The following is a description of a gene set: species: Homo sapiens from publication Yevshin I, Sharipov R, Kolmykov S, Kondrakhin Y, Kolpakov F (PMID 30445619) Genes containing one or more binding sites for (RYBP) in their promoter regions (TSS -1000,+100 bp) as identified by GTRD version 20.06 ChIP-seq harmonization. Human Gene Set: RYBP_TARGET_GENES, and this is the list of marker genes: NFKB2, DUSP26, PRDM16-DT, HSPE1, RPS13, GPATCH8, ZNF24, JUN, HES1, AIDA, POLR2H, GNB2, DOCK9-DT, PLEC, HOXC4, KMT5B, HMGN5, LINC00240, LIMD1-AS1, MTCL1, LBX1-AS1, EP300, GATA3, NBL1, LTA4H, TCTN3, KLC4, SINHCAF, LTC4S, REXO4, NFIC, FAM185A, METTL25, SNORD95, HMGA2, FAM20B, CALM2, STX16-NPEPL1, PLXNC1, PRR5, TESK1, POLR1G, AATBC, TRIM9, CHRNA3, RPL36A, HOXA10, LINC02960, VTRNA1-2, DHRSX, TOR1A, PKN2, SERINC2, STX11, CALB1, METTL15 (methyltransferase 15, mitochondrial 12S rRNA N4-cytidine), BASP1, DOCK9, ZNF8-ERVK3-1, TMOD1, ARF1, AURKAIP1, NUP88, GTF2IP13, COMMD2, GTF2A1-AS1, TIRAP-AS1, TRAPPC2, RNF138, MED30, TENT5C, RTTN, POM121L2 (NCBI Gene Id 94026), GAD1, HIF1AN, AXIN2, MIR4512, MBP, PRKAG2-AS1, CAMK1D, TXNRD1, ABHD15, VGLL2, CDHR1, MSC, CZIB, WBP1, RIMKLB, ANKRD13C, MRPS31, TRABD2A, NISCH, THAP5, CHAC1, TMEM79, AMER1, SPRY4 (NCBI Gene Id 81848), SLBP, TADA3, RTBDN, TTC7A, NEBL-AS1, CSMD2, KIF26A, GOSR2, HSP90AB1, BMS1, TK2, C17orf75 (NCBI Gene Id 64149), RUNDC3A, TTC13, TLN1, EPHA2, CCND2-AS1, WDR11-DT, VWA7 (NCBI Gene Id 80737), RPL12P14, GRIN1, ZNF295-AS1, USP25, ATG12, XPNPEP1, ANG, IGF2BP1, FRMPD4, NPR3, DDX3P2, WDR91, BATF3, RPL27, HOXD8, CNTNAP2, NR1H3, WNT10A, MCIDAS, EXOSC2, UTP11, WBP4, QARS1, CAMK2D, HS3ST2, SEC13, SCD, SDC3, RN7SL688P, DUSP14, ADAMTS9, FAM228B, ALKBH3, PERM1, RGL1, BOLA1, CHUK-DT, RPS29, ZNF165, LINC01547, GRIN2A, ATPSCKMT, DCTPP1, ZNF76, ADSS2, GABRA6, GJB1, KMT2E-AS1, LYPD5, TRMT11, MAPK11, EFEMP1, RPS18, ALOXE3, KCTD16, FAM120B, SPRING1, MRPL3, MRO, ZNF609, XKR9, SLC27A4, DOLK, ABCF1, RRM2, INTS6L, SNX12, H2BC26, ZNF839, SKIDA1, ITGA3, PPM1F-AS1, ACHE, ZNF408, APP, PRDM2, PIKFYVE, SCAPER, VPS29, DLL1, HMX2 (H6 family homeobox 2), SECTM1, SMIM10, MSC-AS1, PHYHIPL, RAB8B, SPAG7, NR4A2, LINC00923, DUSP9, ATF7IP, MSL2, EGLN3, TRPC7, FBXL19, LMX1B, BHLHE40-AS1, RCOR3, CTXND1, HSPA12A, DAB2, TMEM41A, AP1S1, ETNK2, ZNF283, NQO2, RTEL1-TNFRSF6B, SLC35G2, RCOR1, CFLAR, GRM8, SPAG6, INPP4B, DNAJC11, LRRC23, C2CD5, TIMP1, SMC5, MLF2, GPR39, NEIL1, LINC01780, DDX5, CAPNS1, UNC79, TLL2, FBXO31, CORO6 (coronin 6), ANKRD34B, FSTL3, DGAT2, MIR4500HG, GSDMA, WDR36, LINC01918, PDLIM7, RTKN (rhotekin), CXCR4, VPS25, FOXP4, EXOC8, SYT7, SH3GL2, EPC1-AS2, ENY2, IRAK1, UPF2, PTDSS1, TFR2, PSENEN, VSIG10, NR2F2-AS1, DNAJC2, LINC03086, FOSL2, ZNF540, ANKRD19P, EMX2, MAP6, LINC01475, NFIA (NCBI Gene Id 4774), DCAF1, CYB561D2, LRP2, SH3BGRL, EEF1B2, DCP2, IKZF5, THAP9, REL, HNRNPA1, SNAPC5, CABIN1, IFNLR1, ZNF436, VPS26C (VPS26 endosomal protein sorting factor C), CNOT6L, LRRFIP1, CRADD, PFKP, MARCHF3, WNT5B, ZFAND3, COL9A2, SUNO1, BCL11B, PTCHD1, ERCC6, ILF2, COPS2, AP1S3, LONRF3, CACNG4, KCTD10, MTMR4, CYB5D2, NCAM1, DPP9, CXXC5, TNC, SNORA17A, DOCK10, RIPOR1, TMEM121, PI4KA, MED12, TLE3, NUP50 (NCBI Gene Id 26132), DKFZP434A062, PURA, JMJD6, PTEN, MROH1, RPS4X, TM9SF5P, LRRC1, FGFR1OP2, ACBD6, OTUD6B, ZSCAN20, ZWILCH, CDC42SE1, SMG5, NDUFS7, LCN8, SUV39H2, CCDC3, AK5 (adenylate kinase 5), KMT2A, DDX39B-AS1, GPRASP3, VDAC2, NPHS1, EGFR (NCBI Gene Id 1956), PXN-AS1, TTLL7, CENPS-CORT, NPNT, TMUB1, STOML2, AMIGO2, SNRPB, SLC24A1, LINC01586, PCYT1A, ZZEF1, CHD2, GFM2, SLC4A1AP, TMEM132A, COQ6, RABL6, FBN2, CGGBP1, ALDH3A2, SMPD4BP, PIGL, CCNI, MCEE, ENSG00000236846, C2orf76 (NCBI Gene Id 130355), EXOC3L4, UBA5, INTS13, SLC38A1, SOCS2-AS1, C2orf42, SORCS3, SETMAR, ZNF30-AS1, ECHDC2, VTI1A, GNA13, ISL1, WNT3A, SREBF1 (NCBI Gene Id 6720), TRIM25, BCYRN1 (brain cytoplasmic RNA 1), SNHG15, KCTD8, SSBL4P, HTRA1, OPTN, KCNK10, FBLL1, ENSG00000238142, LTBP3, TNK2, CALCOCO1, PAMR1, EIF5A2, ANKRD27, ZBTB45, FIBCD1, PPP6R3, NTRK3, PHF6, ZNF207, FKBPL, NR2F2, DACH2, MIRLET7BHG, TTLL1 (TTL family tubulin polyglutamylase complex subunit L1), SF3A3, MTF2, MAOA, GUCD1, NRAS, RPL5, SMARCD3, OLIG2, LNC-LBCS, STMN3, HMGB1, PROX1-AS1, MNAT1, AOPEP, ZNF629, PSME1, COQ3, PCBP1-AS1, NLRP1, SNHG32, DDX17, RGMB (repulsive guidance molecule BMP co-receptor b), ZNF568, VAMP7, LRRC49 (NCBI Gene Id 54839), PPM1H, MRPL18, SFTA3, PDZD11, EIF1AD, SPX, EXD2, VTRNA1-3, B3GNT7, ATP2A1-AS1, NR2F1-AS1, H4C8, UBC (NCBI Gene Id 7316), ARVCF, SYT6, NRL (NCBI Gene Id 4901), EP400P1, TGFB2, TPRG1L, LEMD1, CRIP2, LARP4, MFSD4A, HLA-F, PPP1R3B, WDR83, NPR1, NDUFA4L2, EMB, LASP1, LRP3, CZIB-DT, POLK, TMEM17, FAM161A, PRKCZ, UAP1L1, SAXO5, ZNF607, ETV4, JKAMP, LINC01556, LINC01117, PRKAR1A (protein kinase cAMP-dependent type I regulatory subunit alpha), STUM, HECW1, FOXO4, RAB3IP, KAZN, AFF1, DHPS, TEDC1, LIMCH1, PPP6R1 (NCBI Gene Id 22870), NCOA7, MKRN5P, NUP133, TMSB15B-AS1, ATP4A, TOB2P1, PRKCE, TSSK3, WLS, MRPL16, STING1, FKBP10, DPF1, TMEM69, GPR161, S1PR5, MBNL3, AGAP2 (ArfGAP with GTPase domain, ankyrin repeat and PH domain 2), SNTG2-AS1, TMED5, GATAD1 (GATA zinc finger domain containing 1), MAGEC2, HOXA7, LINC01415, SNHG7, IGF2-AS, IGF2BP3, WASF4P, ZNF516-AS1, DUSP6, JMJD1C, TFAP2E, TBCB, TYW1, PIP4K2A, IQCH, ADK, PNPLA6, WWOX, MAGEH1, CIDEA, BRCA2, PPP2R2C, WWC2, IGDCC3, ENAH, UBE3B, NTNG1, C10orf88 (NCBI Gene Id 80007), PDE6D, EDRF1-DT (EDRF1 divergent transcript), NME1-NME2, CHPT1, MRGBP, PDE4A, EFCAB7, EPHX1, HMGXB4, ATOH8, SNTG2, NDUFB3, POLR3E, RNFT2 (NCBI Gene Id 84900), MEGF8, MRPS11, HAR1A, MIR6853, RPS26P11, TSPAN12, CNIH3-AS2, CNKSR2, ASIC2, EPHB1, PTPN21, CALY, EHBP1L1, TAF15, SAMD4B, SMG8, VIRMA-DT, MTARC1, GRIK3, JPX (JPX transcript, XIST activator), PTMA, FOXP4-AS1, PARD6A, MAPT, SFSWAP, PSD (pleckstrin and Sec7 domain containing), SEPTIN4, ZNF248, CCKBR, SEMA3B, SNHG5, ATP1B1, ZDHHC6, H3C9P, SPIN1, VWA5B2, PPP1R12A, AJUBA-DT, SPA17P1, LRFN2, AKAP9, GPS1, SP7, P2RX1, INHBB, GSDME, RBSN, ECI2-DT, MYL6, ESAM, PPP5D1P, SMCR8, PECR, RNF157-AS1, SMARCD2, NMNAT1, FAM98B, CCT6B, TRIM45 (tripartite motif containing 45), KLHL21, PLK2, PLXNB3 (plexin B3), NKD2, MSX2, ACOT7, SUDS3, WTAP, NEURL1B, GAS6-DT, NPTX1, CKLF-CMTM1, PTPRS (NCBI Gene Id 5802), MGST3, CCDC122, ADSL (NCBI Gene Id 158), CHEK2, FBXL7, TLE2, KIFC3, SNHG18, SCNN1A (NCBI Gene Id 6337), PVALEF, COX8A, NSA2, CD24, WDR75, EP300-AS1, LSR, CNIH3, LINC01023, TRIM7-AS2, RNU6-9, EMX2OS, S100A2, GBF1, STRA6, FGF9, PSMC2, HCG14 (NCBI Gene Id 414760), RNY3, PTPN12, FIGNL2-DT, PPP1R13L, SACM1L, RNF207, MIF4GD-DT, TAF7, L1CAM, SLC4A11, CELF4, SPOP, TPR, MKX, HSPD1, TNFAIP3, REL-DT, GABPA, RAB27B (RAB27B, member RAS oncogene family), DHX40, ASCC1, LLGL2, KAT5, U2SURP, MIR378A, IKZF2, CREB3, AP3M2, MBLAC2, DIP2C, TFAP2A, SMARCAL1-AS1, HOXB3, COG2, SLC35B1, PSMD3, NOP16, NRP2 (neuropilin 2), HSPA6, LINC01686, SDCCAG8, RNASE11, SGSM2, SLC13A4, GABPB2, ALDH1A2-AS1 (NCBI Gene Id 283665), RNF187, ACE2, DCDC2, C8orf58, F3, ZNF473, PDZD7, MIS12 (MIS12 kinetochore complex component), CASKIN2, INTS14, PRSS16, SPRTN, TPRN, ELOVL1, KMT2D, AASDH, MIR616, HS3ST6, H2BC27P, CERT1, RHBDF1, ANTXR1, ELAVL2, RBM15, LINC00475, OSBPL1A, EDNRB, COX16, NEMP1, EFNA2, MTR, TTC9B, NHSL2, GLIPR1L2, EPIST, ZCCHC7, CHCHD2P6 (coiled-coil-helix-coiled-coil-helix domain containing 2 pseudogene 6), ST3GAL5, SOX3 (NCBI Gene Id 8256), PRPH, RNF25, H2AC25, SHH, NBR1, MIDN, RBBP7, LINC02136, SUFU, SMARCC2, GLI3, KLRG2, WEE2-AS1, TUBGCP6, VSTM2A, ARRDC4, VCPIP1, RPL32, CBR3-AS1, MBD6, CDKN2D, HCN4, C3orf38, BRF2, DNM1P35 (dynamin 1 pseudogene 35), PALS1, MCM10, ALDH1A2, DCP1A, PCGF1, PRAF2, AGBL5-AS1, BTK, LRRC20, VPS51, ERO1B, TIMM9, PIM1, NOG, SLC30A3, STK11, PLAUR, NUMBL, RETSAT, MIR200CHG, DHDDS, SHTN1, DLL4, TSEN54, FOXJ1, EIF3A, PRDM8, EMC3-AS1, SYN3, HNRNPU (NCBI Gene Id 3192), PTPRG, TBC1D19, NDUFA4, CPNE5, DDX47, ENPP3, RBM4B, NPDC1, PIGM, BTG2-DT, NPY, TRPC5, VSNL1, GARS1-DT, THBS3-AS1, ENTPD2, ADGRF2P, FBXO38-DT, FRA10AC1 (FRA10A associated CGG repeat 1), LINC01623, IGBP1, UBE2I, MOAP1, SPATA2L, KIT, COL19A1, CCDC59, FGF13 (fibroblast growth factor 13), PITPNM1, ENSG00000255647 (novel transcript), CBX4, TMEM259, EIF3F, AJUBA, SAR1B, CYREN (NCBI Gene Id 78996), ASAH2B, CCND3, EZH1, TLR5, PPP1R14C (NCBI Gene Id 81706), DMRTA2, TM6SF1, CCDC97, EOLA1-DT, MPHOSPH10, RPL4, SH2D5, FOXA2, VWA1, RAB3IL1 (NCBI Gene Id 5866), DAXX, NUP54, GATA6, SSBP4, CACNB3, LGI4, CAMK2N1, CAPS2, PPP2R3C (protein phosphatase 2 regulatory subunit B''gamma), C5orf34, NSL1, STYXL1, YIPF3, COPS7B, DPF3, RIPPLY2, SLC39A3, CD99L2, DBI, RNF220, PTOV1, COL4A6, PHACTR1, RPP38, ZNF131, INTS10, ECEL1, PPP4R3B, NUP153, BNIP1, CCDC18, ELP2, RERG, PADI1, MICB, ADRB1 (NCBI Gene Id 153), JARID2, CDK5RAP3, DNAAF11, HYCC2, TCP1, CCDC124, RASSF10-DT (NCBI Gene Id 105376557), TOP3A, AEBP2, PARP2, ZNF503-AS1, FIBP, FUZ, SNX2, CWC27, FXYD7, ARPC4, UBAP2, PDE11A, ANKRD13B, NIM1K, MIF4GD, SS18, SASH1, ERCC6L2, WRAP53, CITED1, ICAM4-AS1, HELT, CDK14, LINC03126, PLK3, FLVCR2, LINC02361, SPATA41, TRIM41, APTX, SERTAD3, E2F2, RAD9B, KDM3A, SLCO4A1, RASAL2, FTCD, OBI1-AS1, MCUB, RPTOR, HMCN2 (hemicentin 2), TRPA2P, NXT2, DDX39B, CXCL12, SLC35G1, ZNF846, EXO1, TOP3B, PICART1, PITPNM3, KCNH3, HAUS5-DT, BRPF1, MEPCE, HTR5A, POU4F2, BLOC1S1, DHX33-DT, TAP1, LRMDA (leucine rich melanocyte differentiation associated), TARDBP, TRPV4, ENSG00000176984, TTC5, SEC22B, ABCG4, DIRAS1, ANK3, KCNJ5, ZEB2-AS1, GABBR2, SLC25A53, RN7SKP114, ZBTB8OS (NCBI Gene Id 339487), BPHL, ARPC4-TTLL3, ZNF8-DT, LRPPRC, CSF1, STK36, SMAD7, PLXDC1, ALG10B, PPID, SNRPB2, RRP8, ENTPD1-AS1, IARS1, SH3RF3, ATE1OSP, FOXK2, SKOR2, TICRR, LITATS1, GALNT16-AS1, RAPGEF1, ANKRD40, RTL9, VTRNA2-1, NT5C1A, KRT8, PRORP, RET, ENSG00000224905, WAC, RUBCNL, SFR1, PCNT, GFI1B, GAS2L1, GLI1, GPBP1L1, TEFM, NFASC, HSCB, LTN1 (listerin E3 ubiquitin protein ligase 1), ST6GALNAC2P1, KHSRP, CDIP1, UNC45A, HOXA-AS3, KANSL3, SPAG8, KIAA0586, ZBTB40, NUP188 (nucleoporin 188), ZSCAN12, KNL1, TAPBP, NMB, RNY4, FBXO38, SNORA73A, RN7SK, CCN1, COL15A1, PPEF1, TSPAN31, HDAC1, OAS3, PPARG, MARCKSL1, DYSF, APBA2, MEF2C, SLC29A3, CITED2, NUP50-DT, TBC1D16, ARHGAP1, CHFR, CNTRL, ZNF862, PAN2, LINC02698, RNY1, DGUOK-AS1, KIF4A, PEX3 (NCBI Gene Id 8504), ELMOD1, GDF7, DCLRE1A, MZT2A, SEZ6L, ADCY8, COL24A1, FAAP20, CCDC177, MDH2, MAX, CCDC117, AGBL5, COQ8B, GUCY1B1, CREBL2, TCHP, IGFBP3, TRIM14, KLF2-DT, LSM5, MATK, KRTDAP, CLVS2, POLR1C, NCOR2, CIMIP6, AACS, ENSG00000283183, NUP133-DT (NUP133 divergent transcript), TMEM242, LINC00265, CCND2, PRKCZ-DT, LAMA1, METTL26, HEBP2, ARHGAP4, STOX1, ZFP36, PLEKHO1, FAM32A, GALNT14, EDRF1, MDM2, LINC01116, STRIP2, MRPS31P5, NKX6-2, PAK3, HOMER2, PRRC2C, LINC00620, IREB2, RN7SL1, B4GAT1, PVALB, GMDS, ISLR2, SLC29A1, SFMBT2, FLT4, SBDS, COMMD1, PIANP, DNAJB2, TMEM202-AS1, RANBP17, TSPO, DCAF11, ZNF382, PGD, ZNHIT3, NEFL, ZNF561, H4C4, SBDSP1, CT75, CDC7, HELLS, BCL11A, PCLAF, GFRA2, LPAR1, PXDN, ZNF227, FMC1, INSRR, BAZ1A-AS1, VTRNA1-1 (vault RNA 1-1), KCNF1, EPB41L4B, BANF1, KLHL28, CLUAP1, C15orf40 (chromosome 15 open reading frame 40), CTSC, DAP, CTDSP2, INTS11, LINC01775, CORO7, DRG2, SGMS1, NAPG, GSN, SLC43A1, BRI3BP (BRI3 binding protein), PLEKHG2, DNER, TRPC4, BHLHE40, CRLF1, KCNQ4, RNASE4, RGS5, APBA1, AP3S1, MARVELD1, ACD, B4GAT1-DT, RHBDD2, ACADL, RNVU1-1, SNX33, SNORA14B, RGS9BP (NCBI Gene Id 388531), BCL7C, CYP1A1 (cytochrome P450 family 1 subfamily A member 1), KRT13, FBXO17, TOX4, SLC12A9, ATRAID, MED26, CHAT, ADAMTS7P4, ARL15, SEMA3G, MIR3939, MED16, AAGAB, ARMCX6, ERMP1, NQO2-AS1, SOX14, ADAP2, NBAS, STAT3, NR4A1, SOX6, GRAMD1A, NDRG1, SYTL4, BHLHE22-AS1, LHFPL4, FSD1L, IRS4-AS1, DEPDC1B, ANKRD34A, POLG, ZNF711, OTUD6B-AS1 (OTUD6B antisense RNA 1 (head to head)), RUSC1, DMAP1, GOSR2-DT (NCBI Gene Id 105371798), PSMF1 (proteasome inhibitor subunit 1), SP6, P2RX6, FAM133B, MIR6821, LINC00963, HOXA5, ILK, SF3B6, MIR4734, GSR, FHL1, TAFA2, MAGEE2, LINGO1, PCSK1, ZNF461, VRK3, TSR1, PPP4R3B-DT, SLC35E4, BMP4, INSIG2, GABARAP, HES2, ID3, ZNF35, POLR2I, FSCN1, TMX3, RPS15, PER1, PLEKHD1, DIP2A, RAB29, MPP1, LINC00663 (NCBI Gene Id 442764), NOL8, GARS1, HOXD11, CYB5R4, MTIF2, SP2-AS1, SATB2-AS1, NKX2-1, PHACTR2, PRMT5, RPAIN, STAG2, TMEM105, TNS3, OLFM2, CBR1, NEMF, GBA1LP, CDC42EP4, UBE2L6, ENSG00000247416, ARMC3, NDUFAF4P1, SYNGAP1, KIF26A-DT, PPP1R18, RPP38-DT, DCAF8, ZEB2, IL23A, ZNF383, PLEKHF1, RPL37A, MDH1, NOC3L, RRS1-DT, COSMOC, ELANE, ACTR1A, CCDC107, IGF2, SLC8A3, PDCD6, RAB2B, KLF2, VPS52, DSC2, HJV, UBB, ZNF592, MRPL2, PARD3B, ITGB3BP, ETV6, BCAR3, SNORA9, TSC1, LINC01210, SNRPD3 (small nuclear ribonucleoprotein D3 polypeptide), EGR3, EMC4, ELMOD3, SPAG16-DT, GRIA4, GINS3, ZNF30, TMEM242-DT, S100A10, AHSA2P, SLC27A6, STK10, RARG, PRKCG, SMG7-AS1, PLXNA2, ATG4B, CYP26A1, NHEJ1, IQGAP2, PRKG1, SPTBN4, NAB2, PTPRB, QKI, BROX, PCED1B, RPL36A-HNRNPH2, BHLHE41, PHLDB3, ADCYAP1, RBL1, NINJ1, DGAT2-DT, SLC16A2, KY, TAF6, GPRC5C, SPAG16, CYP2R1, NANOS3, GHET1, NPC1 (NCBI Gene Id 4864), TTC4, THAP10, RPS26, ENSG00000233332, MYO3A, CIRBP, CRHR1, CNPY4, WDR11, FAM53C (NCBI Gene Id 51307), NRG4, NKX6-1, TATDN3, MCRIP2, EXOSC3, TBX1, PSMB10, GCC1, ZNF221, OTULINL, RFX4, ATAD1, LINC00471 (NCBI Gene Id 151477), ALG10, MIR4497, MNT, SH3RF2, FOXL1, THAP9-AS1, FEZF2, RPS7, PCDH7, MITD1, RPLP0, MAGEC1, KDSR, DDX18, NVL, PTH2, ISY1-RAB43, ZNF536, HAR1B, RPS14, DGCR8, TTLL13, TCF3 (NCBI Gene Id 6929), KIF20B, ITGA7 (integrin subunit alpha 7), JARID2-DT, VPS13B, WAC-AS1, ERCC6L2-AS1, MAST1, CCT5, SNORD84, FAM131B, SCAND2P, SNHG17 (small nucleolar RNA host gene 17), CCNB3, APLP1, DLX2, MIR124-3 (NCBI Gene Id 406909), NR3C1, DOC2A, CAPN12, BRCA1, EMC3, HDAC8, SUCO, MPP2, SUPT7L, NHLRC2, ENSG00000235143, TRIM33, SEC16B, POLR3G, SHF, DAPK1, CCT4, MRPL39, HOXC9, ARHGAP22, SNRNP35, OFD1, RTEL1, POLG-DT, MYOM2, RPL10, CLDN23, SMARCAL1, ALDH1L1, TUBA1C, SCYL3, CENPP, ZNF561-AS1, NPAS1, FAM242C, ATP5PF, LAMB2, C9, SDE2, RACK1, FAM98C, RRS1, SNORD48, CDC42BPA, OLFM1 (NCBI Gene Id 22825), P3H4, HSD11B2, SORBS1, ZNF793, ADORA1, MAP1LC3B, ENSG00000268129, ADAM19, PNPO, DDN (dendrin), CDKL3, ANKRD13C-DT, CISD1, NDRG2, CFL1P1, APOO, ZNF234, COL4A5, CASC15, NPRL2, MRPL46, ENKUR, DIPK2B, LMX1B-DT, SLC6A1, NCOA4, SENP1, MGA, LHFPL3 (LHFPL tetraspan subfamily member 3), TMPRSS2, TBL1X, NMI, RIPOR2, WNK3, FGF12-AS2, HAUS7, OXNAD1, CTTNBP2, CFAP46, SKOR1, ERG, NABP1, CAP1, NAV1, CYP27B1, FMC1-LUC7L2, CRYBG2, SLC4A8, BDNF, PFKM, GTPBP3, LZIC, ZNF92, JOSD1, AFF3, C14orf132, PLCD3, ACP2, PPFIA4, LINC02453, NDUFS1, ALKBH2, LINC01770, L3MBTL3, SUB1, MRPL30, GTF2A1, ID4, ARFGEF3 (NCBI Gene Id 57221), WDR89 (WD repeat domain 89), WDR83OS, IER5L-AS1, ADCY7, GABRB2, GLRA1, RHEB, TTL, SEPTIN5, SCN4B, KCNJ2, IRGQ, IPMK, ZNF829, CHRNB4, B9D1, DNM3, EOMES, LTBP4, MEF2C-AS2, TMED2, TBX21, MTPN, APC2, ADD2, ZNF585B, METTL4, USP30, CH25H, VSTM2B-DT, LIPA, GATA6-AS1, HSPE1-MOB4, ZNF337-AS1, RNU6-8, ADAT2, OSCP1, NME1, FGF13-AS1, TRIM36, AMN1, POU3F2, SREK1IP1, RNA5SP89, HOOK2, PGM5P2, LRP10, SNORA17B, LINC01149, SLC37A1, KIF7 (kinesin family member 7), RNU6-1 (NCBI Gene Id 26827), FGD3 (FYVE, RhoGEF and PH domain containing 3), TELO2, HUS1, MIR548AW, ZNF56P, NDC80, TRIM26, PRR3P1, CHD1, POLR3B, TMEM267, SMOC1, FGFR4, DNAJC22, CFAP418, ZNF793-AS1, FOXC1, RPUSD3, KLHL20, TP53I13, SETD1A, TIA1, ZBTB16, GPM6B, ENSG00000253295, CAMKK1, RAB18, ZNF581, ENSG00000232995, NFKBID, DNMT3B, ICAM5, CENPS, ANXA6, DHX33, SLC26A2, BMI1, GATA3-AS1, CC2D2B, BTG2, NRP1, ADCK5, GFY, STMND1, FBXL15, HMGN4, TNFRSF14, U2AF1L4, MRPS16, CCT8, SNAP29, P4HB, PHIP, ZFAND3-DT, PBX3, PLP1 (NCBI Gene Id 5354), TRERF1, ZNF576, TASOR2, HAUS5, IRF4, MORC2, JUN-DT, CLPB, BRWD1, ODR4 (NCBI Gene Id 54953), SSBP1, GFI1, STX16, YME1L1, SEC31A, DSTYK, MAD1L1, RPL30P11, DOP1B, NKAPP1, ERBB3, GALNTL6, SPRY4-AS1, PDE4D, SLC35F2, TARS3, IDH1, NKAIN1 (sodium/potassium transporting ATPase interacting 1), PANTR1, ZNF593, EGLN2, PCBP1, EDIL3, CELF6, MLEC, FRMD5 (NCBI Gene Id 84978), MAN2C1, STX18-AS1, IFFO2, C5orf47, PKNOX1, RASSF8-AS1, POU2F2 (POU class 2 homeobox 2), LRP6, KDM5A, IGDCC4, ZNHIT6, PPM1J-DT, FEV, NUF2, DTL, SHISA5, CEP95, WDR31, POLR2A, IRS1, HOXB2 (NCBI Gene Id 3212), TMED3, IGFBP2, TOR1AIP1 (torsin 1A interacting protein 1), SDHAF3, CYP51A1-AS1 (CYP51A1 antisense RNA 1), CTPS2, SLX9, RASGRP4, HNRNPUL1, GAPDHP71, RPL36, MTERF3, SSTR2, CENPU, CEP170, LINC02739, TRIP4, MIR4536-1, ZNF268, DPH3, RPPH1, NOX5, HROB, TRIM67 (tripartite motif containing 67), PHKA1, KIAA1191, MIR4521, NGFR, WAKMAR2, SIX1, SLC25A39, ADAMTS8, VSTM2B, NDUFAF1, MTSS1, CRABP2, ARMC8, NUP85, WNT6, B3GALT6, NXPH3, CCDC77, NKX2-3, BCL2, SCRN2, ESPN, GTF3C3, CYP26B1, INPPL1, ZNF879, PHB1, CALCB, MIR3202-1, KIAA0930, TBX6, DLX2-DT, CBX5, MFAP2, CDK5R1, STX18, EEFSEC, ZHX2, NCAPD3, RASAL2-AS1, HEMK1, GCGR, SETD7, SOCS2, ABTB3, UBE2Q1, ACTN1, ACAD11, RBM45, WDR62, GALK2 (galactokinase 2), SLC6A14, ISY1, ZAR1L, ASPHD2, VEZF1, FAM131C, EDIL3-DT, MASTL, EOLA1, GSTA4, CKLF, SERTAD3-AS1, PSMB3, TMEM72-AS1, PBX3-DT, HOXB-AS1, ACTR6, CEP43, CCDC102B, CKB, DCLRE1C, PRNT, CYP51A1, RASGRF2-AS1, DERL2, MED23, KLHL22, TAGLN2, SEPTIN7P2, RAP1GAP2, SMG7, TET1, KISS1R, RANGRF, NR2E1, L3HYPDH, RGMB-AS1, TRIB2 (NCBI Gene Id 28951), SLC39A6, TMCO1, AAR2, BCL2L11, PDXK, HS6ST2, FER1L4, NEUROG2-AS1, PHLDA1-AS1, ZNF8, NDRG4, PRR35, RFC1, CAND2, GRAMD1A-AS1, MLLT6, ANK3-DT, CHST11, RAB11A, RNU6ATAC, AKAP7, ENO2, KLHL13, TXLNG, ATP8B2, MOCOS, HOXC-AS1, BEGAIN, VPS13B-DT, BNC2, KDM5C, TMEM59L, CDK18, MYNN, PXN, ENSG00000247131, DNAJC6 (NCBI Gene Id 9829), MXRA7, RGMA, VIRMA, ITGA8, STC2, CALM3, BMPR1A (NCBI Gene Id 8035), EBLN3P, PMEPA1, CISTR, ACSF2, TMEM178B, DNAJB9, PTGES, RCC2, RGS6, C20orf96, NOLC1, SLC34A2, TMCC2, WDPCP, MIR5188, PROX1, FOS